Given this list of marker genes ACAA2, AQP3, EPOP, SPP1, CXorf49, MOV10, RPL39L (NCBI Gene Id 116832), LY6G6E, TMEM64, NANOG, NPL, GJB3, H19, PURA, TRIB3, ULK1, TET1, CHCHD10, CYP2S1, RNF17, PSMA8, SLC25A20, RNF125, TEX15, LRRC2, KHDC3L, ASS1, FNTB, MSC, JAM2, FTHL17, ALDH6A1, BCLAF3, ZNF267, KLF2, TM7SF3 (NCBI Gene Id 51768), NFATC2IP, TFCP2L1, TBX3, HSF2BP, COBL, FAM9A, KLHL13, EPAS1, HDAC6, MYBL2, HESX1, HPRT1, BICRAL, SEMA4B, AK7, IMPA2, FABP3, DNMT3L, TM9SF5P, IPMK, PHF11, PLEKHA4, CHAC1 (NCBI Gene Id 79094), ZC3HAV1, ITPR3, MREG, TEX19 (testis expressed 19), FMR1NB, RPP25, PRDM14, MYL11, HTRA1, OTX2, HSD17B14, CDC5L (cell division cycle 5 like), GM2A, OOEP, LIPH, FGF4, SLC39A4, RPAP1 (RNA polymerase II associated protein 1), SATB2, MORC1, PFKP, MT1F, SORD, C15orf48, ZNF254, USP9X, CALCOCO2, MTMR12, TMEM40, ENAH, RDM1, CYCTP, AIRE, LAMA1, UPP1, DNAJC6, SLC29A1, NR0B1, CENPM, KLF4, WNK3, ESRRB, TET2, FBXO15, GABARAPL2, GSTP1, KMT2C, PNMA5, TFPI, MANBA, NPHS1, PCK2, IFITM1, TCL1A, LAPTM5, AGTRAP, here is a description of the gene set: Human Gene Set: PASINI_SUZ12_TARGETS_UP Polycomb group (PcG) proteins form multiprotein complexes, called Polycomb repressive complexes (PRCs). PRC2 contains the PcG proteins EZH2, SUZ12, and EED and represses transcription through methylation of lysine (K) 27 of histone H3 (H3). Suz12 is essential for PRC2 activity and its inactivation results in early lethality of mouse embryos. Here, we demonstrate that Suz12(-/-) mouse embryonic stem (ES) cells can be established and expanded in tissue culture. The Suz12(-/-) ES cells are characterized by global loss of H3K27 trimethylation (H3K27me3) and higher expression levels of differentiation-specific genes. Moreover, Suz12(-/-) ES cells are impaired in proper differentiation, resulting in a lack of repression of ES cell markers as well as activation of differentiation-specific genes. Finally, we demonstrate that the PcGs are actively recruited to several genes during ES cell differentiation, which despite an increase in H3K27me3 levels is not always sufficient to prevent transcriptional activation. In summary, we demonstrate that Suz12 is required for the establishment of specific expression programs required for ES cell differentiation. Furthermore, we provide evidence that PcGs have different mechanisms to regulate transcription during cellular differentiation. Genes up-regulated in ES (embryonic stem cells) with defficient SUZ12. species: Mus musculus from publication Pasini D, Bracken AP, Hansen JB, Capillo M, Helin K (PMID 17339329)